Given this list of marker genes Sox9, Wnt3a, Fgfr2, Sfrp2, Six4, Fgf1, Vangl2, Hoxd13, Ptk7, Ppp2r3a, Wnt5a, Tfap2c, Trim28, Spry1, Yap1, Lrp6, Areg, Med12, Fgf10, Bmp4, Sfrp5, Nat8f3, Tgfb1, Six1, Esr1, Hnf1b, Rdh10, Nkd1, Shh, Spry2, Zfp568, Tnc, Wnt11, Med1, Sfrp1, Tmtc3, here is a description of the gene set: The developmental growth that results in the elongation of a line that defines polarity or symmetry in an anatomical structure. Mouse Gene Set: GOBP_AXIS_ELONGATION species: Mus musculus